The following is a description of a gene set: species: Mus musculus Mouse Gene Set: GOMF_RECEPTOR_LIGAND_INHIBITOR_ACTIVITY Binds to and decreases the activity of the ligand of a signaling receptor., and this is the list of marker genes: Lrrc32, Nrros, Hsp90ab1, Ltbp1, Tmeff1, Igfbp2